The following is a description of a gene set: Human Gene Set: chr1p13 species: Homo sapiens, and this is the list of marker genes: MAB21L3, RNU6-792P, CHIAP3, PGBP, PRMT6, SLC25A24, WDR47, MTATP6P14, BCAS2, RNA5SP54, HENMT1, TSPAN2, RPL7P8, GSTM2, CASQ2, SLC16A4, LINC02868, KCND3, HNRNPA1P43, DDX20, MIR4256, CHI3L2, NRAS, LINC01779, RANP5, PTGFRN, AKR7A2P1, MIR942, AP4B1-AS1, EPS8L3, CNOT7P2 (CCR4-NOT transcription complex subunit 7 pseudogene 2), RPL7L1P21, LINC01397, CELSR2, RN7SL420P, AP4B1, RLIMP2, SYPL2, SPATA42, SCARNA2 (NCBI Gene Id 677766), CYMP-AS1, BCL2L15, LRIG2-DT, CHIAP2, CYMP, LINC02884, KCNC4, TRIM45, MTND5P20, VANGL1, KCNA3, KCND3-AS1, ST7L, GNAI3 (NCBI Gene Id 2773), EIF2S2P5, NGF, ELOCP20, KCNA10, ATP1A1, ENSG00000302765, SORT1, AMPD2, KRT18P57, SIKE1, TAFA3, LINC01661, CTTNBP2NL, LAMTOR5-AS1, PSMA5, RHOC, CHIA, CEPT1, CSF1, NGF-AS1, GSTM1, SLC6A17-AS1, CIMAP3, LINC01356, ST13P21, NBPF6 (NCBI Gene Id 653149), ATXN7L2, INKA2, MOV10, MTCO1P14, ENSG00000238761, LINC01762, NDUFA4P1, CD101-AS1, HIGD1AP12, RBM15-AS1, MRPL53P1, CYB561D1, LINC01649, RSBN1, CSDE1, CD58, STRIP1, RNY1P13, OR11I1P, PTPN22, AMPD1, OVGP1, ENSG00000284830, CAPZA1, AHCYL1, NHLH2, GAPDHP64, DENND2C, SLC22A15, KCND3-IT1, DENND2D, ALX3, GSTM5, EEIG2, MIR548AC, MRPL57P1, CFAP276, AKNAD1, RAP1A, TAF13, RNU6-817P, PPM1J-DT, KCNA2, SYCP1, TMIGD3, SLC25A24P2, C1orf162, RPL13AP10 (NCBI Gene Id 100132906), WDR77, SLC6A17, PKMP1, NBPF5P, RPL17P7, VAV3, CLCC1, MYBPHL, SLC25A24P1, HIPK1, FNDC7, ENSG00000207502, MAGI3, TTF2, FTH1P22, NEFHP1, GPSM2, GNAT2, RPS15AP9 (NCBI Gene Id 441898), PROK1, NDUFA5P10 (NCBI Gene Id 102724853), GPR61, LAMTOR5, VAV3-AS1 (VAV3 antisense RNA 1), GSTM3 (glutathione S-transferase mu 3), TRIM33, KCNC4-DT, ENSG00000287103, HIPK1-AS1, TXNP3, RN7SL432P, ENSG00000221040, NRBF2P3, CD2, CCNT2P1, SYT6, PSRC1, MIR320B1, MIR197 (NCBI Gene Id 406974), ELAPOR1, RPS27P6, AMIGO1, IGSF3, SLC16A1-AS1, NR1H5P, ATP5PB, SARS1, CD53, OLFML3, NAP1L4P1, TSHB, TMEM167B, CHIAP1, UBL4B, LINC01750, CD101, LRIG2, GSTM4, LINC01160, NUTF2P4, SLC16A1, INKA2-AS1, RNA5SP55, TMEM167B-DT, STXBP3, DRAM2, RBM15, UBE2FP3, ADORA3, PHTF1, NTNG1, MIR7852, LINC01765 (long intergenic non-protein coding RNA 1765), ATP1A1-AS1, WNT2B, RNU7-70P, LINC01768, LRIF1, PRPF38B, DCLRE1B, RNU6V, RNU6-151P, PPM1J, NBPF4